Given this list of marker genes Adam10, Lgals9, Ch25h, Xcl1, Slc8b1, Cklf, Cyp7b1, Klrk1, Cxcr3 (C-X-C motif chemokine receptor 3), Slc12a2, Ccl3, Cxcl11, Cxcl14, Wnk1, Ccr7, Plec, Il4, Wnt5a, Gpr183, Cxcl10, Nedd9, Cx3cl1, Cxcl16, Ccl12 (C-C motif chemokine ligand 12), Adam8, Oxsr1, Ccl7 (NCBI Gene Id 20306), Ccl2, Adam17, Cxcl12, Ptk2b, Hsd3b7, Tmem102, Ccl21a, Msmp, Tnfsf14, BC037156, Ccl26, Cxcl13, Gas6, Ccr2, Stk39, Ccl5, Padi2, Gpr15lg, here is a description of the gene set: The directed movement of a lymphocyte in response to an external stimulus. Mouse Gene Set: GOBP_LYMPHOCYTE_CHEMOTAXIS species: Mus musculus